Given this list of marker genes KCNA7 (NCBI Gene Id 3743), TAL2, NRP1, TRIP13, ACTR3, FHL1 (NCBI Gene Id 2273), CLNS1A, TUBB6, TEK, SLC25A53, SLC11A2, VTA1, ZNF322, LY86, A2M, ANGPT2, RBKS, CD5L, STMN3, KRT32, JUP, AK1, GNAZ, NOCT, FSHB, TOR1AIP2, FOXB1, RGS4, APOC2, IL13RA1, B4GALT6, IL15RA, MGAT3, AQP2, POU1F1, SNHG6, ZC3H12C, PHOX2B, VWA7, RTL6, CTSS, GTPBP4, TIMP3, PRL, MGP, CELSR2, LPL, CIB1, DDX4, CTSE, PSCA, LRPPRC, CHD8, TAGLN, ISOC1, TMEM176B, PIPOX, YWHAH, RPL39L, RAD23B, AGAP1 (ArfGAP with GTPase domain, ankyrin repeat and PH domain 1), BCHE, ZDHHC5, PMM1, RGS3, TIMM44, HAND1, PLIN2, CYP2B6, SERPINB2, PIP4K2C, TEP1, PLAC8, MAP6, SLC7A8, HSPBP1, FOLR2, NPAS1, AKR1E2, NKIRAS2, TGDS, IFT88, ME1, C8G, ZIK1, TFF2, IGF1R, LY6E (NCBI Gene Id 7999), TNFRSF18, NDRG1, FAM83G, ZKSCAN3, CCR5, FCGR1A, PGF, PSMC3IP (NCBI Gene Id 51769), CYTIP, ITGAM, MYPOP, AIF1, C3AR1, BAG2, ANG (angiogenin, NCBI Gene Id 283), SELENOV, DTNB, PIGA, FLNB, PRUNE1, DNAJB13 (DnaJ heat shock protein family (Hsp40) member B13), KLF12, KCNA3, TMEM129 (NCBI Gene Id 92305), FKBP9, BGN, FKBP10, COL1A1, PFKFB1, PTTG1, B9D1, ALDH18A1, LPP, FUT7, CLDN2, JAG2, ANKRD49, IFIH1, FER, CP, CALCR, SPPL2B, ADAM8, YES1, HIF1A, DNAJA1, COL5A2, PHOX2A, ENTPD6, ZBED3, PRNP, TM7SF2, EFNA3, NCBP1, RGS16, TUBA1C, CMTM4 (NCBI Gene Id 146223), PRKCG, ITPK1, ROPN1L, RSAD2, WFS1, KARS1, OLFM1, IKBIP, VNN1, MMP12, TMEM150A, SHISA5, NFKB1, DBNL, SLC22A23, ERGIC1, TWIST2, KRTCAP2, FOXA2, PHKB, COMMD9, RDH5 (NCBI Gene Id 81991), B4GALT3, CCR3, HK2, H19, FAM162A, PIM3, SEPTIN1, HIVEP3, FAM117A, ZNHIT2, PAM, SYT4, HPGD, ACTN1, MBD6, MYH4, CLIP4, IL10, TM4SF1, SERPINE2, MAPK6, TPPP3 (NCBI Gene Id 51673), ANGPTL2, FKBP5, MPO, ITGAV, SGCD, AMBRA1, NOC4L, LCT, CTSK, NOS2, FGD1, here is a description of the gene set: Human Gene Set: GSE43955_1H_VS_42H_ACT_CD4_TCELL_WITH_TGFB_IL6_DN Genes down-regulated in CD4 T helper cells Th17 treated with TGFB1 and IL6: 1h versus 42h. Despite their enormous importance, the molecular circuits that control the differentiation of Th17 cells remain largely unknown. Recent studies have reconstructed regulatory networks in mammalian cells, but have focused on short-term responses and relied on perturbation approaches that cannot be applied to primary T cells. Here, we develop a systematic strategy – combining transcriptional profiling at high temporal resolution, novel computational algorithms, and innovative nanowire-based tools for performing gene perturbations in primary T cells – to derive and experimentally validate a temporal model of the dynamic regulatory network that controls Th17 differentiation. The network is arranged into two self-reinforcing and mutually antagonistic modules that either suppress or promote Th17 differentiation. The two modules contain 12 novel regulators with no previous implication in Th17 differentiation, which may be essential to maintain the appropriate balance of Th17 and other CD4+ T cell subsets. Overall, our study identifies and validates 39 regulatory factors that are embedded within a comprehensive temporal network and identifies novel drug targets and organizational principles for the differentiation of Th17 cells. studied in species Homo sapiens from publication Yosef N, Shalek AK, Gaublomme JT, Jin H, Lee Y, Awasthi A, Wu C, Karwacz K, Xiao S, Jorgolli M, Gennert D, Satija R, Shakya A, Lu DY, Trombetta JJ, Pillai MR, Ratcliffe PJ, Coleman ML, Bix M, Tantin D, Park H, Kuchroo VK, Regev A (PMID 23467089)